The following is a description of a gene set: The process in which ions are transported across a membrane such that the cardiac muscle cell plasma membrane potential changes in the direction from the positive membrane potential at the peak of the action potential towards the negative resting potential. species: Mus musculus Mouse Gene Set: GOBP_MEMBRANE_REPOLARIZATION_DURING_CARDIAC_MUSCLE_CELL_ACTION_POTENTIAL, and this is the list of marker genes: Kcnn2, Kcna5, Kcnd3, Kcne1, Kcnj2, Flna, Kcne2, Kcnj8, Rnf207, Kcne3, Kcnh2, Kcnh6, Kcnq1, Dlg1, Scn2b, Kcnj5